The following is a description of a gene set: from publication Chen Y, Wang X (PMID 31504780) species: Homo sapiens Human Gene Set: MIR543 Genes predicted to be targets of miRBase v22 microRNA hsa-miR-543 in miRDB v6.0 with MirTarget v4 prediction scores > 80 (high confidence targets)., and this is the list of marker genes: LRRN1, SRSF7 (NCBI Gene Id 87459), C16orf95, RABGEF1, MTX2, TRMT9B, CLOCK, LRATD2, HS3ST3A1, VPS13B, FAM117A, TNFSF11, VIP, MSR1, UBA2, GK5, EYA1, AKAP7 (A-kinase anchoring protein 7), LRRC58, HEY2, IFT74, COPS2, C15orf48, LINC02693, IQCJ-SCHIP1, MTF2, PLA2G4A, EIF1, MRPS14, FMNL2 (formin like 2), ZNF597, ANO5, KIN, CYB5R4, CALHM4, HOOK1 (hook microtubule tethering protein 1), GOLGA6L10, CREB1, DCP1A (NCBI Gene Id 55802), WASL, FRYL, BRD1, RASSF10, ZNF345, GPCPD1, VBP1, SLC25A21, RABL3, ARNT2, RASAL2, CD302, PRKG1, IL1A, PDE5A, MTA1, C5AR1, GOLGA8J, EIF4A2 (eukaryotic translation initiation factor 4A2), NPM1, ARL5A, ZNF419, TMF1, CREG2, RBM26, CTTNBP2NL, PDAP1, COLEC10, WNK3, TRPM7, PREX2, FGF12, GRM8, DOP1B, PF4V1, GATM, TCF7L2, GTSE1, DACH1, REPS2, AVPR1A, GOLGA8T, FKBP4, UFD1, PRTG, ING1, CCDC28A-AS1, AKAP6, PTPN4, THUMPD1, TMEM263, QKI, TAX1BP1, SLC10A7, MFSD2A, ZFAND4 (NCBI Gene Id 93550), PPP2R2C, CASK, YTHDC1, TWIST1 (twist family bHLH transcription factor 1), MRPL13, KLF6, LY75-CD302, CTDSPL, GOLGA8B, MSI2, ZNF367, E2F7 (E2F transcription factor 7), IFT80, BACH2, TXLNA, CTSC, PLEKHA8, FAM13B, KCNC2, OTUD1, GAPVD1, ADGRB3, LIFR (LIF receptor subunit alpha), KAT6A, OSBPL3, PCSK1, HGF, MIA2, MRPS18C, ARHGEF26, L3MBTL4, SNX18, ZZZ3, KCNQ5, ATP10A, ITGB8, RBM47, RAB11A, ATP1B1, METAP2, MTMR12, METAP1, FHIP1B, NWD2, GID4, ANKRD13C, ABHD13, LRRC8D, OPRM1 (opioid receptor mu 1), TESMIN, ZNF131, MAPK1 (NCBI Gene Id 5594), GALNT3, HEG1, FAM133B, LZTFL1, MACIR, PLAG1 (NCBI Gene Id 7996), WASF1, RNF13, NR3C1, AMER2, UBE2W, TEX2, C2orf69, PCSK5, DLX1, PLXDC2, NADK2, CACNB4, SH3TC2, SLC12A5, TNPO1, RNF7, SCG2, CADM2, SNAPC3, TRIM23, GOLGA6L9, CCDC117 (coiled-coil domain containing 117), CNTNAP3, ATG5, RP2, DYNC1LI2, FZD4, FBXO34, CYP26B1, TXK, NMT2, MATR3, AKAP5, ANKRD50, ZBTB43, DPY19L3, SLC39A12, PDZD11, KLHDC10, AHCTF1, ZNF74, GOLGA8R, CCDC112, ZFHX4, JMY, GOLGA6L4, GABRA1, EEIG1, ZBTB34, SAMD5, BAZ2B, PPP4R3B, PEAK1, PPP4R2, ZNF566, ACYP1 (NCBI Gene Id 97), GOLGA8H, C21orf91, LPP, FHIP1A, HIGD2A, FOXP2, GHITM, RPE65, SH3GLB1, CEP97, EPS8, CHML, ONECUT2, PPA1, CDH8, DCLK1, SORD, SLC7A11, GOLGA8Q, DMRT3, DHRS9, KLHL5, UNKL, RNF6, STRBP, GPBP1, ST6GALNAC3, MTARC2, KRBOX5, DHX15, TBC1D9, OSBPL2, IRF5, COX11, CREBRF, EREG, GABRB2, SIPA1L1, MEGF10, KCNMA1, PSG9, SIX2, RAB30 (NCBI Gene Id 27314), GBP1, KIF3A, ELOVL2, YBX3, TMEM252, RUFY2, CCDC141, ACVR1C, NR1D2, KCNA1, ADAM9, PKD2, MCTP2, ZNF704, CCDC88C, ZNF280D, NANP, AQP4, ENSG00000286190, MDFIC, BIRC6, RORA, ID4, ING5, CD163, SEL1L, LMO1, ALDH9A1, ARHGEF3, SPTY2D1, CNTNAP3B, CBLL1, FASTKD1, MTCL1, GOLGA8A, IKZF5, PER3, HIPK2, PPP3R1, GOLGA8M, CDH2, SIRT1, PSIP1, ZDHHC3, HSPA12A, SLC16A6, ZNF711, CCAR1, B3GALT1, ITPR2, GDA, C19orf12, SERPINI1, SLC38A4, STT3B, PAK5, WNT16, NAALADL2, MANEA, PIAS1, HECA, GOLGA8N, SS18L1, FIGN, NFAT5, SELENOT, CSRP3, KDM5A, TBC1D1, BCL6B, TCERG1, DMXL2, RBM46, EEA1, TTBK1, OSBPL8, BMP2K, CGGBP1, PHIP, GRIK2